The following is a description of a gene set: species: Homo sapiens Underdevelopment of the thymus. Hypoplasia of the thymus Human Gene Set: HP_HYPOPLASIA_OF_THE_THYMUS, and this is the list of marker genes: PEX5, PLXND1, ARVCF, RORC, ATM, LTBP4, PI4KA, G6PC3, TTC7A, MCM10, JMJD1C, TBX1, SEC24C (NCBI Gene Id 9632), SKIC2, WAS, FREM2, TP63, RAG2, ORAI1, GP1BB, DCLRE1C, POLR1C, NKX2-6, COMT, POLR1D, WIPF1, RREB1, NSMCE3, NEK9, UFD1, POLR3A, SKIC3, HIRA, RAG1, POLR1B, AK2, IL2RG, TCOF1